Given this list of marker genes Slc22a6, Slc25a21, Slc13a2, Slc22a7, Slc25a11, Slc13a3, here is a description of the gene set: Mouse Gene Set: GOMF_ALPHA_KETOGLUTARATE_TRANSMEMBRANE_TRANSPORTER_ACTIVITY studied in species Mus musculus Enables the transfer of alpha-ketoglutarate from one side of a membrane to the other. Alpha-ketoglutarate (or oxoglutarate) is a compound with important roles in carbohydrate and amino acid metabolism, especially in transamination reactions and as a component of the TCA cycle.